Given this list of marker genes CDC23, RBX1, PSMB5, PSMC1, PSMA7, ANAPC1, PSMD7, PSMB3, ANAPC4, ANAPC7, PSMC5 (proteasome 26S subunit, ATPase 5), SEM1, CCNA2, ANAPC11, ADRM1, PSMD13, ANAPC15, ORC6, MCM3, PSMB2, PSMB4, MCM4, MCM5, PSMA5, PSMC6, MCM2, ANAPC10 (NCBI Gene Id 25866), UBC, ORC4, UBB, CDC6, MCM7, ANAPC5, UBE2D1, ORC5, UBE2C, PSMA2, PSMD1, MCM8, CDK2, CCNA1, ANAPC16, GMNN, PSMA3, CDC26, ANAPC2, PSMA1, CDC16, PSMD3, ORC3, CDC27, CDT1, FZR1, PSMA6, UBA52, RPS27A, CCNE1, ORC1, PSMD6, PSMB6, PSMD2, PSMC2, CUL1, PSMB1, UBE2S, PSMD8, CCNE2, SKP2, PSMC4, PSMD14, PSMD12, SKP1, PSMD11, PSMA4, MCM6, PSMB7, ORC2, UBE2E1, PSMC3, here is a description of the gene set: Human Gene Set: REACTOME_SWITCHING_OF_ORIGINS_TO_A_POST_REPLICATIVE_STATE Switching of origins to a post-replicative state studied in species Homo sapiens